The following is a description of a gene set: Human Gene Set: GCM_CHUK studied in species Homo sapiens Neighborhood of CHUK Neighborhood of CHUK conserved helix-loop-helix ubiquitous kinase in the GCM expression compendium, and this is the list of marker genes: SIN3A, OTUD6B, DENND4A, MTMR4, MED17 (mediator complex subunit 17), GNA13, MTPN, TBC1D14, POLDIP3, ASCC1, TBC1D10B, SH2B1, COMMD9, SPTLC1, GPBP1, SPDL1 (spindle apparatus coiled-coil protein 1), ABHD16A, TSNAX, ANAPC5, MRPS5, CAB39, METTL17, FBXL20, PCNP, TAF9B, DENR, CHD9, CCAR1, YME1L1, C1orf52, ZNF274, DCLRE1C, LEMD3, FOXN3, TMX3, RBM25, ACOT8, PRPF8, NF2, TEX261, PCF11, MORF4L1, CS, KLHL18, RPL7L1, IPO5, STAMBP, TMEM167B, TBC1D22B, DDX47, OCIAD1, ING1 (NCBI Gene Id 3621), ALKBH5, TMED5, COQ10A, PTCD3, PSME3, PIP4P1 (phosphatidylinositol-4,5-bisphosphate 4-phosphatase 1), UBR7, NXF1, TOR1AIP1, UBE2G1 (ubiquitin conjugating enzyme E2 G1), EIF4EBP2, SLTM, BOD1L1, SUMF2, MTMR7, GFM2, MOB4, TADA2B (NCBI Gene Id 93624), CHUK